The following is a description of a gene set: from publication Xie X, Lu J, Kulbokas EJ, Golub TR, Mootha V, Lindblad-Toh K, Lander ES, Kellis M (PMID 15735639) Comprehensive identification of all functional elements encoded in the human genome is a fundamental need in biomedical research. Here, we present a comparative analysis of the human, mouse, rat and dog genomes to create a systematic catalogue of common regulatory motifs in promoters and 3' untranslated regions (3' UTRs). The promoter analysis yields 174 candidate motifs, including most previously known transcription-factor binding sites and 105 new motifs. The 3'-UTR analysis yields 106 motifs likely to be involved in post-transcriptional regulation. Nearly one-half are associated with microRNAs (miRNAs), leading to the discovery of many new miRNA genes and their likely target genes. Our results suggest that previous estimates of the number of human miRNA genes were low, and that miRNAs regulate at least 20% of human genes. The overall results provide a systematic view of gene regulation in the human, which will be refined as additional mammalian genomes become available. Human Gene Set: GGARNTKYCCA_UNKNOWN Genes having at least one occurrence of the highly conserved motif M163 GGARNTKYCCA in the regions spanning 4 kb centered on their transcription starting sites. The motif does not match any known transcription factor binding site. species: Homo sapiens, and this is the list of marker genes: NTRK3, ITGA1, MRPL45, CD86, RASGEF1A, MAP4K2 (NCBI Gene Id 5871), RAMP2, MEF2D, HSPG2, MED1, UBR5, TNFSF18, CLTRN, CLDN17, PPM1D, C19orf73, SRPX (NCBI Gene Id 8406), RORC, SKIL, PELO, PIK3IP1, AP5B1, OGT, ABRAXAS2, GABRE, FXYD2, CGB7, TMEM37, SLC6A9 (NCBI Gene Id 6536), NIM1K, GPR119, NELL2, GJD2, MANEAL, KLK9, ZNF503, SCAMP1, COL1A2, PPFIA3, HOXB4, SKI, CCN1, PTGES, MSX1, CGB2, LINC00310 (long intergenic non-protein coding RNA 310), DLGAP4, DNAJA1, CEND1, CSMD3, ST8SIA1, ETV4, SCRT2, RAB37, DNAJB5, EGF, MAP3K8, HCN1, PHF6, NEUROD4, GPR158, NFIB, GPM6A, VEGFA, ATP1B3, SOCS2, CEMIP, XPO1, STIP1, NPDC1, IFNB1, SPAG9, TTLL11, MRPS6, DDX17, MITF, CPLX2, CHPF, FERD3L, CAPN9